The following is a description of a gene set: Mouse Gene Set: GOBP_NITRIC_OXIDE_MEDIATED_SIGNAL_TRANSDUCTION An intracellular signaling cassette that starts with production of nitric oxide, detection by receptors/sensors for nitric oxide (such as soluble guanylyl cyclase/sGC) and ends with the activation of downstream effectors that further transmit the signal within the cell. Nitric oxide transmits its downstream effects through either cyclic GMP (cGMP)-dependent or independent mechanisms. species: Mus musculus, and this is the list of marker genes: Atp2b4, Kdr, Cbs, Ins1, Npy2r, Ins2, Gapdhrt, Nos3 (nitric oxide synthase 3, endothelial cell), Cd36, Rilpl1, Mt2, Gucy1a2, Spink1, Apoe, Gapdhrt2, Mt1, Ndnf, Nos1, Rln1, Nos2, Vegfa, Thbs1, Kcnc2, Rasd1, Agtr2, Gucy1a1, Gucy1b1, Gapdh, Pde5a, Pde2a